The following is a description of a gene set: Mouse Gene Set: GOBP_POSITIVE_REGULATION_OF_DEVELOPMENTAL_GROWTH studied in species Mus musculus Any process that activates, maintains or increases the rate of developmental growth., and this is the list of marker genes: Bcl2, Dio3, Tbx1, Slc6a3, Serpine1, Drd2, Adnp, Sptbn4, Sgip1, Prox1, Dscam, Vegfa, Pafah1b1, Unc13a, Rps6kb1, Igf1r, Il7, Csf1, Igf2, Myo5b, Parp2, Pin1, Tnfrsf12a, Celf1, Ghr, Ghsr, Arhgap32, Gata6, Flt3, Lpar3, Rims2, Capn3, Rpl4, Cdh4, Wnt3, Tbx20, Sema4d, Bbs4, Akap6, Insr, Bmpr2, Smo, Plaa, Hopx, Dlg1, Musk, Ppib, Plcb1, Nrg1, Hlx, Map1b, Hsf1, Ntn1, Dcx, Trpc5, Map3k13, Fxn, Nrp1, Sash3, Akt1, Dbnl, Adrb1, Hnrnpk, Ncam1, Fgfr2, Ngf, Rasal1, Yap1, Nr3c1, Tbx2, Ptger4, Creb1, Cyfip1, Megf8, Shtn1, Syt2, Mef2c, Chd7, Cacna2d2, Gdi1, Gpr21, Fdps, Cxcl12, Stat5b, Limk1, Mir675, Syt1, Sema5a, Eif4g2, Wnt2, Cdk1, Smad7, Adcy10, Igf1, Pim1, Nedd4l, Vil1, Cpne9, Sh3pxd2b, Hmga2, Wnt5a, Rnf157, Pls1 (plastin 1 (I-isoform)), Syt3, Atp8a2, Afdn, Srf, Pou3f2 (NCBI Gene Id 77364), Syt4, Efna5, Actn3, Bmp10, Serp1, Cxcr4, Wt1, Gh, Gata4 (GATA binding protein 4), Smurf1, Slc25a4, Arx, Edn1, Gpam, Cpne5, Hamp2, Ikzf1, Sema7a (sema domain, immunoglobulin domain (Ig), and GPI membrane anchor, (semaphorin) 7A), Sox15, Rag2, Pum2, Myod1, Nipbl, Ghrhr, Cdkl5, Hamp, Fgf2, Tgfbr3, Gli1, Reg1, Macf1, Picalm, Zp3 (zona pellucida glycoprotein 3), Ilk, Ddx39b, Rufy3, Pin1rt1, Islr2, C3, Syt17, Disc1 (NCBI Gene Id 640053), Agt, Ccnd2, Pak1, Prkdc, Zfpm2, Sirt1, Dll1, Tbx5, Trpv2, Tshr, Pex5, Mtor, Wnt3a, Ep300, Slc23a2, Fn1, L1cam, Trip10, Rbpj, Zfyve27, Mul1, Hey2 (NCBI Gene Id 30802), Erbb4, Foxs1 (NCBI Gene Id 14239), Fgf8, Rnd2 (Rho family GTPase 2), Gsk3b, Bmpr1a, Sh3glb1, Prkn, Pou4f2, Twf2, Agr2, Fgfr1, Ccnb1, Lrp1, Stat5a, Pou1f1, Dbn1, Apoe, Mtm1, Mapt, Mkks, Ist1, Ghrh (NCBI Gene Id 14601), Eif2b2, Fgf9, Notch1, Ntrk3, Cacng7, Rims1, Ezr, Bdnf, Bbs2, Ybx3, Cpne6, Itsn2, Mapk1, Ccn4, Adrb2, Mapk14, Crabp2, Bcl11a, Acacb, Golga4, Lep, Mecp2, Agrn, Anapc2, Ppard, Ndel1